Given this list of marker genes MBNL1, SCAF11, HOXA2, RPF2P1, ZBTB37, IGFALS, OTC, BTK (NCBI Gene Id 695), MTREX, ZNF334, CA3, NFIA, SOX21, SPIB, SLC13A1, PCDH9, EPHA7, RAB1A, RERE, ZNF385B, DAB2IP, NR1D1, FAM13C, GPRIN3, NR4A3, HECTD2, PCDH11Y, GPSM2, TFDP2, BEND6, THAP11, ITGA10, TSSK3, RXRB (NCBI Gene Id 6257), CD151, DHX29, GPC6, ATP2C1 (NCBI Gene Id 612), TPMT, PAX2, SFTPC, PRMT3, PCDH8, FBXW7, KIRREL1, TNFRSF8, SUN5, ARID4A, GFI1, ANK2, VSIG2, KLF3, HAPLN1, ORMDL3, IMP3, STX17, GLRA2, BPIFB2, PLA2G1B, IL18 (interleukin 18), UBA1, OPALIN, SEMA6A, TLE4, EVA1A, SMURF1, FOXP2, AUTS2, FAM53C, SLC29A1, CNN1, SFSWAP, NEUROD2, UBE2H, SEZ6, ACAN, BTG1, SVIL, JARID2, MBNL2, SYNCRIP, TSR1 (TSR1 ribosome maturation factor), RARG, TAPBP, TOB1, OLIG2, SPPL2A (NCBI Gene Id 84888), NFIX, GPM6A, MICALL2, CD96, AFF3, RBM47, OTX2, NAP1L5, KRT31, NAA60, BHLHE41, LRRFIP2, ZC3H10, PURA, DNAJA3, KCNQ1 (NCBI Gene Id 3784), GFRA1, TGIF1, ANKS1B, FEZF2, USP5, TYRO3, PDZD2, IL1RAPL1, TAB3, MYCL, ITSN2, MATN4, SLC35A2, RPL41, CALD1, GALK2, KMT2D, TNMD, MNS1, DENND2D, SERINC2, MITF, SLC25A16, ITPR3, ATP11AUN, ITPKB, SLC25A51, KLF7, GRPR (gastrin releasing peptide receptor), MYLK, PUM2, SCUBE1, TIMP4, GRIK1, ARHGAP44, KRT36, ZIC5, GARRE1, MSI2, DCDC1, LIN54, CALCR, RELCH, C1orf122, ARHGEF38, EBF2, TRIB1, SLC39A7, ZNF282, ORAI3, VSNL1, ITIH6, ATP4A, DUSP6, TCF21, SOX4, TBXAS1, ROS1, ADTRP, DCHS1, NMRK1, KCNIP3, RBFOX1, PCDH11X, RFX3, POU2AF2, GOPC, ITIH1, JPH4, HS3ST3A1, MCAM, PTCH1, GRIN2B, EPS8L2, FOXD3 (NCBI Gene Id 373071), PCDH17, SMARCA2, MGAT4B, DRD3, SLC5A3, E2F3, PLXNA2, ELF4, ESRP2 (epithelial splicing regulatory protein 2), TRAPPC14, UNC13D, IGSF9B, SCML1, DMD, CPN1, OLFML3, DDX17, MACO1, FABP1, SNX9, TSHZ3, YRDC, KRT17, MXI1, ANKRD30BP2, LUC7L, GPLD1, SKAP1, MIDEAS, PTPRG, PPARGC1A, LMO3, GANAB, E2F1, SORBS2, RBPJL, CDK2AP2, FOXN3, TAFA2, CRACR2B, MYOZ2, CLEC4D, MACROH2A1, MORF4L2, PACSIN3 (protein kinase C and casein kinase substrate in neurons 3), CCDC30, SLC2A12, ITGB3BP, ENHO, SLITRK2, ADAMTS9, JADE1, MAP4K5, CHST1, FCGBP, BARHL1, EFNA5, NLK, RPS27L, MN1, GIPR, ARRB2, UBALD2, ERICH5, ATP5F1B, CD93, ATOSB, PPP2R2A, CRY2, DLG2, GBX2, COLGALT2, SOX14, ERG, DHX30, ZEB2, PLAG1, MAGEH1, BTBD3, HOXA3 (NCBI Gene Id 3200), MID1, KCTD6, KLF3-AS1, NFAT5, SLC6A9, SRPK2, SERPINA1, here is a description of the gene set: Genes having at least one occurrence of the motif AGCAHAC in the regions spanning 4 kb centered on their transcription starting sites. This matches the DBP transcription factor binding site V$DBP_Q6 (v7.4 TRANSFAC). Human Gene Set: DBP_Q6 species: Homo sapiens